The following is a description of a gene set: from publication Cairo S, Armengol C, De Reyniès A, Wei Y, Thomas E, Renard CA, Goga A, Balakrishnan A, Semeraro M, Gresh L, Pontoglio M, Strick-Marchand H, Levillayer F, Nouet Y, Rickman D, Gauthier F, Branchereau S, Brugières L, Laithier V, Bouvier R, Boman F, Basso G, Michiels JF, Hofman P, Arbez-Gindre F, Jouan H, Rousselet-Chapeau MC, Berrebi D, Marcellin L, Plenat F, Zachar D, Joubert M, Selves J, Pasquier D, Bioulac-Sage P, Grotzer M, Childs M, Fabre M, Buendia MA (PMID 19061838) Genes up-regulated in hepatoblastoma samples compared to normal liver tissue. Hepatoblastoma, the most common pediatric liver cancer, is tightly linked to excessive Wnt/beta-catenin signaling. Here, we used microarray analysis to identify two tumor subclasses resembling distinct phases of liver development and a discriminating 16-gene signature. beta-catenin activated different transcriptional programs in the two tumor types, with distinctive expression of hepatic stem/progenitor markers in immature tumors. This highly proliferating subclass was typified by gains of chromosomes 8q and 2p and upregulated Myc signaling. Myc-induced hepatoblastoma-like tumors in mice strikingly resembled the human immature subtype, and Myc downregulation in hepatoblastoma cells impaired tumorigenesis in vivo. Remarkably, the 16-gene signature discriminated invasive and metastatic hepatoblastomas and predicted prognosis with high accuracy. Human Gene Set: CAIRO_HEPATOBLASTOMA_UP studied in species Homo sapiens, and this is the list of marker genes: HSPA2, PODXL, GJA1, LYZ, DLK1, TUFT1, MARCKS (NCBI Gene Id 4082), MLEC, PDCD2, ZFTA, TMEM243, BEX1, PSEN2, RNF38, PEG10, MAP3K4 (mitogen-activated protein kinase kinase kinase 4), POLR1D, CDK4, FRRS1L, HDAC2, RHOBTB1, MEG3, CEP68, UTRN, PRKD1, CDC23, HEATR1, CYP51A1, MMP11, PDXK, RPS6KC1, GLUL, ITGAE, PLXNC1, NDN, PDGFA, CKAP4, TIA1, VPS45, PPP1R2, PRKCA, PRR15L, ANKRD27, OBSL1, KDM5B (lysine demethylase 5B), ASPSCR1, PIEZO2, TBX3, LEF1, SREBF2, SP3, ACACA, EMCN, SNHG32, FNBP1L, AKR1C3, UNC119B, IGF2BP2, TULP4, NAP1L1, GSTA4, PLAG1, MCAM, KHDC4, TNKS, WFS1, DLG5, RAB4A, EPCAM, PLPPR1, SOCS5, SLC26A2, LAMC1, MTR, PSMD4, BAMBI, RBM34, DKK1, CLMN, ROCK2, MRPS27, SMYD2, MINPP1, GABBR1, RC3H2, LRRC1, SQLE, CRIPTO, EHMT2, FASN, JARID2, ACSS3, MARCHF8, UXS1, HIP1, CRIM1, SMYD3, HMGN4, HMGCR, TRIB2, RPA1, VWF (von Willebrand factor), PLVAP, PRUNE1, CD24P2, SERPINE2, FDFT1, CAP2, R3HDM1, PPP1CC, HMGA2, CREB3L2, CBX1, UBAP2, PMS1, SOX4, HSPB1 (heat shock protein family B (small) member 1), CD46 (CD46 molecule), ETV1, SCD, NSDHL, CLIC1, TACC1, TOR3A (torsin family 3 member A), CS, SMARCC1, RACGAP1, MAP4K4, ITGA6, ZBTB38, DDHD2, CBX6, RBM12, GNPAT, BCAM, DRAM1, PSMD10, TAX1BP3, SUCO, PALLD, MAGED1, SAC3D1, BRD3, DENR, DCP2, SEPHS1, GPC3, PFKM, CBX5, MAVS, RRP1B, TSN, POMK, NUP37, PAPSS1, FKBP1B, TP53, ELP1, UBAP2L, FXR1, CAMSAP2, ACLY, ANGEL2, HMGCS1, RAP2A, MPZL1, DZIP3, ARL4A, TBCE, RCOR3, NUP133, ROBO1, SMARCA4, SLC1A4, SLC25A36, ILF2, NCOA3, MAGED2, HSP90AB1, FDPS, LGR5, COL15A1, ERG28, SLF2, NUDT3, ALCAM, TSPYL4, CKB, AVL9, SEPTIN2, TBC1D9, TOMM20, IMPDH2, MCM3, CCT3, UGGT1, ZNF189, TARBP1, PEG3, CETN2, RNF43, ASAP2, RELN, GMNN, KDM3B, SEPTIN8, GREB1, PDZK1, CPD, RANGRF, MFF (NCBI Gene Id 56947), GORASP2, CD24